Given this list of marker genes Cyp4f13, Cyp4f14, Adtrp, Abcd1, Cyp4f15, Lipe, Cyp4f18, Aig1, Cyp4f40, Acadl, here is a description of the gene set: studied in species Mus musculus Mouse Gene Set: GOBP_LONG_CHAIN_FATTY_ACID_CATABOLIC_PROCESS The chemical reactions and pathways resulting in the breakdown of a long-chain fatty acid. A long-chain fatty acid has an aliphatic tail containing 13 to 22 carbons.